Given this list of marker genes COX17, SIRT3, GCH1, INS, NPR3, SNCA, FGF23, ESR1 (estrogen receptor 1), EDN2, CDH3, EDN1, RFK, here is a description of the gene set: Any process that activates or increases the frequency, rate or extent of oxidoreductase activity, the catalysis of an oxidation-reduction (redox) reaction, a reversible chemical reaction in which the oxidation state of an atom or atoms within a molecule is altered. Human Gene Set: GOBP_POSITIVE_REGULATION_OF_OXIDOREDUCTASE_ACTIVITY species: Homo sapiens